Given this list of marker genes CMPK2, CPT2, IFIH1, SLC2A1, SNORD118, SAMHD1, NAA60, TREX1, ESAM, here is a description of the gene set: The presence of calcium deposition in the cerebral white matter surrounding the cerebral ventricles. Human Gene Set: HP_INTRACEREBRAL_PERIVENTRICULAR_CALCIFICATIONS studied in species Homo sapiens Intracerebral periventricular calcifications